The following is a description of a gene set: from publication Szanto A, Balint BL, Nagy ZS, Barta E, Dezso B, Pap A, Szeles L, Poliska S, Oros M, Evans RM, Barak Y, Schwabe J, Nagy L (PMID 21093321) studied in species Homo sapiens Human CD14 positive monocytes were purified from healthy volunteers’ blood and cultured in vitro for 4, 12, 24, 72 hours. While culturing, macrophages were activated alternatively with interleukin-4 (IL-4 100 ng/ml) or classically with interferon-gamma (IFNg 100 ng/ml)+tumor necrosis factor (TNF 50 ng/ml) or left without activation. Simultaneously, macrophages were also treated with vehicle (DMSO:ethanol) or 1mM synthetic PPARg agonist, Rosiglitazone. We used Affymetrix microarrays (U133Plus 2.0) to analyze activation and PPARg-induced gene expression changes. Genes down-regulated in macrophages (12h): control versus IFNG and TNF. Human Gene Set: GSE16385_UNTREATED_VS_12H_IFNG_TNF_TREATED_MACROPHAGE_DN, and this is the list of marker genes: NIBAN1, NFATC2, RNF144A, ITPA, RFT1, CXCL9, ADRB2, NEURL3, MRPL46, C4BPB (complement component 4 binding protein beta), ZNF285, GIPC1, TIMM44 (NCBI Gene Id 93111), PPP4R2, TRNAU1AP, PRSS16, ALDH3A2, ELMOD3, IER3, PTK2, ZNF382, PIK3AP1, CORO1C, SLAMF7, RPL22L1, MRPS18C, RAD23B, KRT36, G3BP1 (NCBI Gene Id 10146), IFNG, TCEAL3, CHST2, ENTHD1, CEP15, TOB1, DNAJB4, UHRF1, EMG1, RAB31, POLR1C, ANK3, PPP1CB, GALNT1, NPDC1, OR2L13, CXCL10, RNASEH2C, SND1, RSU1, BCL7A, MLEC, DEF8, KLHL23, SCN9A, TAS2R14, DDX21, WSB2, LACC1, RIOK2, ABI1, EPS8, EMC2 (ER membrane protein complex subunit 2, NCBI Gene Id 9694), MEAF6, RPS21, SNAPIN, KBTBD11, HSP90AA1, RAD51C, PLPBP, DPP3, LEF1-AS1, ATP6V1D (ATPase H+ transporting V1 subunit D), YBEY, RAD51D, RARS1, TBCB, ZNF530, BASP1, COQ10B, PLPPR5-AS1, PIK3R6, NCL, FUT7, TMEM237, CNDP2, PRKAR1B (protein kinase cAMP-dependent type I regulatory subunit beta), CALR, HMGN2 (NCBI Gene Id 94860), SLC12A9, NAGK, KIAA1671, FAM241A, NFE2L1, ARPC5L, GTDC1, SSTR5, MYL2, ABHD17C, NIFK, CEP126, CD83, MAPK9, TMED7, ASAH2B, TLK1, EXTL2 (exostosin like glycosyltransferase 2), MICOS10, STK39, FSCN1, BRIX1, HOMER1, MAN2B1, SLC41A2, C12orf43, FICD, HNRNPA3, NAMPT, TPR (translocated promoter region, nuclear basket protein), SYNCRIP, DERL2, B3GNT2 (NCBI Gene Id 55878), ZNF876P, MALT1, TASL, HERPUD1, ORC6, CPLANE1, CST6, BCAT1, MMP7, IL12RB2, MTERF3, TEPSIN, GSDME, FNBP1L, OR7E36P, MBP, WIPI1, C3orf38, TTC5, IRX1 (iroquois homeobox 1), MTFMT, CXCL3, CLIC2, GNG11, CCT6A, KIF11, NIPA2, FAM118B, RABEPK, DGCR5, CNP, RIPK2, COL16A1, ARHGEF10, MTPAP, TIMM8B, SMC3, SMIM15, ACTL10, HSPA13, MTCL2, ZFP69B, LINC00667, SETD1A, BRCA2, TIMD4, ZNF219, BATF, EML5, EXOSC6, ZNF438, BATF3, ANG, ASRGL1, CCND1, ARID3B, LINC01553, U2AF1, KRTAP4-1, MCFD2, DSCC1, MAGOHB, SMU1, TSPAN5, SLC39A4, EOMES, MRPL21, CCL8, SLC38A7, MPC1, APOL3, MT1X, NOP2, FXYD7